Given this list of marker genes PPP2R5C, OCSTAMP, FAM168A, HARS2, PLOD2, CCL28, SSBP2, SPIN1, MCM10, MAML1, PHACTR2, GCNT1, MAP3K9, PCDH7, BOK, KRT6C, EIF5A2, RIMS3, SPAG16, RHOA (ras homolog family member A), PITPNM3, JPH1, PAPSS2, CRIM1, SYNCRIP, UBTD2, LUC7L3, NF1, APOOL, ADCY9, OXNAD1, PPM1E, DIAPH1, CAMK2G, RAB5C, NRAS, UTY, MAPK1, XPO6, NIPSNAP3B, INVS, SLC30A4, IDO2, ADAM22 (ADAM metallopeptidase domain 22), ZC4H2, PAPPA, RPAIN, PPTC7, NCOA1, ALDOB, CAMKV, RBM34, CELF4, LSAMP, CEP15, GAREM1, NHLH2, TYRP1, ZRANB1, TYW3, MAPK1IP1L, GEM, TGFB3, SORBS2, GAPVD1, GARIN6, SH3BP5, RBFA, ACTR2, BSN, UBE2W, KCNH2, GOT2, USP25, HRH1, KCTD15, ZNF281, DDX3X, ADRA1A, ZFP91, TMEM68, DIXDC1 (NCBI Gene Id 85458), FKBP5, SGCB, UBE2D3, MYOZ3, MAPK8IP3, EVI5, SERPINB2, PPM1H, MLLT1, CTNNA3, GNAS, SELENOK, NFRKB, IL17RD, SYNRG, KDM2A (lysine demethylase 2A), SIPA1L2, NRM, IKZF2, ZNF362, KCTD8, here is a description of the gene set: Human Gene Set: MIR2278 Genes predicted to be targets of miRBase v22 microRNA hsa-miR-2278 in miRDB v6.0 with MirTarget v4 prediction scores > 80 (high confidence targets). from publication Chen Y, Wang X (PMID 31504780) species: Homo sapiens